The following is a description of a gene set: Mouse Gene Set: GOMF_MICROTUBULE_SEVERING_ATPASE_ACTIVITY species: Mus musculus Catalysis of the reaction: ATP + H2O = ADP + phosphate. Catalysis of the severing of a microtubule at a specific spot along its length, coupled to the hydrolysis of ATP., and this is the list of marker genes: Katnal2, Fignl2, Fign, Katnal1, Katna1, Spast, Fignl1